Given this list of marker genes Amotl2, Casp3, Stk4, Mob1b, Dvl2 (dishevelled segment polarity protein 2), Stk3, Amot, Wwc1, Wwtr1, Amotl1, Sav1 (NCBI Gene Id 80625), Nphp4, Tjp2, Lats1, Mob1a, Ywhae, Ywhab, Tjp1, Lats2, Yap1, here is a description of the gene set: Signaling by Hippo studied in species Mus musculus Mouse Gene Set: REACTOME_SIGNALING_BY_HIPPO